Given this list of marker genes Arc, Ephb2, Slco2b1, Gja8, Gjb4, Peg10, Gjb2, Mip, Gjb6, Gja3, Map3k8, here is a description of the gene set: The movement of substances between cells. Mouse Gene Set: GOBP_INTERCELLULAR_TRANSPORT studied in species Mus musculus